The following is a description of a gene set: Mouse Gene Set: chr18E1 species: Mus musculus, and this is the list of marker genes: St8sia3os, Mir5107, Spink13, Lman1, Gm20294, Cplx4 (NCBI Gene Id 225644), Grp, Sh3tc2, Impa2, Gm38165, Gm24504, Gm46637, Gm41760, Csf1r, Gm8887, Gm29860, Gm36804, Csnk1a1, Gm25834, Camk2a (calcium/calmodulin-dependent protein kinase II alpha), Cep192, Piezo2, Tubb6, Gnal, Mir6982, Cep76, Prdx1-ps, Mc4r, Fech, Gm24679, Lncbate10, F730048M01Rik, Prelid3a, Gm24848, Tcof1, Pcyox1l, Cdx1, Gm22219, Txnl1, Adrb2, Mir122, Gm30018, Gm25150, Gm6789, Grpel2, Rps2-ps10, Ablim3, Gm22210, 2700046A07Rik, Gm36368, Gm29966, Nedd4l, Il17b, Gm36092, Mir694, Psmg2, Bvht, 4930549G23Rik, Afap1l1, Apcdd1, Carmn, Gm23581, Gm6974, Gm26403, Rps15-ps3, Slc26a2, 1500015A07Rik, St8sia3 (ST8 alpha-N-acetyl-neuraminide alpha-2,8-sialyltransferase 3), Gm19784, Fbxo38, Atp8b1, Alpk2, A330084C13Rik, Gm19159, Ccbe1, Gm15958, Onecut2, Cd74, Spink7, Cidea, Zfp532, Raxos1, Mir145a, Gm9926, Arhgef37, Pde6a, Gm46618, Gm8755, Hmgxb3, Gm8731, Gm30094, Sec11c, Gm17669, Spink10, Amd-ps3, Mir6983, Oacyl, Chmp1b, Mppe1, Pdgfrb, B430212C06Rik, Gm6978, Seh1l, Gm41757, Ppargc1b, Gm45934, Arsi, Spire1, Slc6a7 (NCBI Gene Id 240332), Afg3l2, Pmaip1, Rax, Ptpn2, Mir143, Napg, Gm26972, Malt1, Gm30190, Nars1, Mir7220, Gm19076, Htr4, Gm41750, Mir378a, Wdr7